Given this list of marker genes Grin1, Grin3b, Glra1, Grik5, Gabrp, Chrna10, Chrna5, Chrnb2, Chrna3, Glrb, Gabrr2, Chrnb3, Gabra6 (gamma-aminobutyric acid type A receptor subunit alpha 6), Grik2, Grin2c, Chrna1, Gria1, Chrnd, Gria2, Gabrg2, Chrnb4, Chrna2, Chrna9, Gabrq, Glra3, Gabrg3 (NCBI Gene Id 70716), Glra4, Grin2d, Gabrg1, Chrna4, Gabra1, Grin2b, Grin2a, Glra2, Grin3a, Gabrr1, Gria3, Gabra3, Gabrb3, Grik3, Grik4, Chrna6, Htr3a, Gabrd, Grik1, Grid1, Grid2, Chrne, Chrna7, Htr3b, Gabra5, Gabre, Gabra4, Gabrb2, Gria4, Chrng, Chrnb1, Gabra2 (gamma-aminobutyric acid type A receptor subunit alpha 2), Gabrb1, here is a description of the gene set: Mouse Gene Set: GOMF_TRANSMITTER_GATED_CHANNEL_ACTIVITY Enables the transmembrane transfer of a solute by a channel that opens when a specific neurotransmitter has been bound by the channel complex or one of its constituent parts. studied in species Mus musculus